The following is a description of a gene set: Genes having at least one occurrence of the motif HWAAATCAATAW in the regions spanning 4 kb centered on their transcription starting sites. This matches the ONECUT1 transcription factor binding site V$HNF6_Q6 (v7.4 TRANSFAC). Human Gene Set: HNF6_Q6 species: Homo sapiens, and this is the list of marker genes: ING2, POGZ, NEK11, STAT3, ZNF711, SEMA3A, HOXC6, SST, ARL6IP1, UNG, RBFOX1, SSH3, INPP4B, ZPLD1, MAPK8IP1, HOXA11, MBNL1, RUNX1, C6orf62, NUP107, NPR3, ANKRD1 (NCBI Gene Id 27063), SULF2, HTR3B, C1orf122, KCTD15, DLX2, ZIC3, NDST4, ZDHHC9, ATP6V1H, FNBP4, PRR34, HOXB9, BNC2, NOVA1, TNF, GABARAPL2, PITX1, IGF2BP1, AGPAT4, DAAM1, ARRDC3, XPR1 (xenotropic and polytropic retrovirus receptor 1), CHCHD7 (coiled-coil-helix-coiled-coil-helix domain containing 7), CAST, NIPBL, TSHZ2, PAX8, NRG1, TLE4, EPN3, VLDLR, SLC6A9, FLRT3, EBF2, GRIN2A, SLC25A13, MEF2C, GPBAR1, CADM1, DCTN1, SLC12A2 (solute carrier family 12 member 2), CHD2, PPP1CB, IL1RAPL1, OTP, BRINP1, TAFA1, CALN1, CDH10, CCL2, ESM1, ASTE1, NFIX, PDZK1, PDGFRA, JARID2, HNF4G, KLHL1, COL25A1, CCND2, NSD1, TPP1, TMEM88, SPINK1, ORC4, ETV4, HDX, YRDC (NCBI Gene Id 79693), GNAO1 (NCBI Gene Id 2775), ZIC1, SIPA1, CDAN1, FFAR2, CSMD3 (CUB and Sushi multiple domains 3), PCDH17, TWIST1, LMTK2, SGIP1, UCKL1, NTF3, LINC01597, PRICKLE2, LMO4, NEUROG1, STOML2, CCDC88A, OGG1, COL13A1, RAI2, CHN2 (chimerin 2), OR2K2, SP8, CA10, EDN1, SIAH3, CPNE1, HCN1, MROH2B, LBX1, GRIK2, GUCA1C, ZIC4, LRRN3, SH2D1A, PRDM13, THRA, CELF4, MITF, DCDC1, PDZD2, CBX3, HNRNPA2B1, PLAG1, HOXD10, SYT6, BBOF1, TTR, GAL3ST4, GRM3, SIX1, MAT2A, SLITRK1, SLC17A6, TECTA, CNBD1, NHLH2, NECAB3, PREX2, HSD17B14, CD68, AK8, SOX4, CUX1, SRPK2 (NCBI Gene Id 6733), ADGRL2, JAZF1, SAMTOR, BCL11B, ARK2N, NEUROD2, POU4F2, CDH16, GPR85, MAB21L2, NMNAT3, NR2C2, JPH4 (junctophilin 4), NLN, ADGRB3, DAB2 (NCBI Gene Id 1601), POU2F1, TDRD5, ANKRD28, NRAS, WNK1, PAX3, TSPAN6, ZHX2, HOXC4, TRMT112, TSHZ3, TSPAN33, MIR137HG, RARB, TLE1, PAX9, S100PBP, ZNF827, TOB2, RCAN2, MTMR6, HERC4, TOB1, BHLHE41, GTF2F2, ARHGEF12, ZC3H11A, CLDN14, RERE, SALL1, BAMBI, CDH6, WASL, CLSTN2, MSTN, LTA, HOXA3, GEN1 (NCBI Gene Id 348654), PIK3R1, PLPPR1, PRDX5, FGF8, PHOX2B, FBXO11, MN1, LRMDA, MTUS1, FAM83F, PDZRN4, OTX2, PFN2, CDH9, AP1S2, CNTN4, SPACA9, GSX1, MTMR11, SGTB, TTC17, KCNAB1, HBP1, FABP4, DGKG, ZNF532, ABI1, CACNA2D3, HABP2, ZC4H2